Given this list of marker genes ITFG1, CES1, LPCAT2, MAF, PHKB, VPS35, CES1P1, CDH8, DNAJA2, WWOX, CAPNS2, CDYL2 (chromodomain Y like 2), GPT2, CNTNAP4, SLC6A2, MMP2, SHCBP1, CES5A, DYNLRB2, MYLK3, ORC6, NETO2, GNAO1, IRX6, C16orf87, ANKRD26P1, here is a description of the gene set: We analysed chromosome 16q in 106 breast cancers using tiling-path array-comparative genomic hybridization (aCGH). About 80% of ductal cancers (IDCs) and all lobular cancers (ILCs) lost at least part of 16q. Grade I (GI) IDCs and ILCs often lost the whole chromosome arm. Grade II (GII) and grade III (GIII) IDCs showed less frequent whole-arm loss, but often had complex changes, typically small regions of gain together with larger regions of loss. The boundaries of gains/losses tended to cluster, common sites being 54.5-55.5 Mb and 57.4-58.8 Mb. Overall, the peak frequency of loss (83% cancers) occurred at 61.9-62.9 Mb. We also found several 'minimal' regions of loss/gain. However, no mutations in candidate genes (TRADD, CDH5, CDH8 and CDH11) were detected. Cluster analysis based on copy number changes identified a large group of cancers that had lost most of 16q, and two smaller groups (one with few changes, one with a tendency to show copy number gain). Although all morphological types occurred in each cluster group, IDCs (especially GII/GIII) were relatively overrepresented in the smaller groups. Cluster groups were not independently associated with survival. Use of tiling-path aCGH prompted re-evaluation of the hypothetical pathways of breast carcinogenesis. ILCs have the simplest changes on 16q and probably diverge from the IDC lineage close to the stage of 16q loss. Higher-grade IDCs probably develop from low-grade lesions in most cases, but there remains evidence that some GII/GIII IDCs arise without a GI precursor. Genes in discrete regions of loss within 16q region detected in individual invasive breast cancer tumors. species: Homo sapiens Human Gene Set: ROYLANCE_BREAST_CANCER_16Q_COPY_NUMBER_DN from publication Roylance R, Gorman P, Papior T, Wan YL, Ives M, Watson JE, Collins C, Wortham N, Langford C, Fiegler H, Carter N, Gillett C, Sasieni P, Pinder S, Hanby A, Tomlinson I (PMID 16702952)